The following is a description of a gene set: species: Mus musculus Mouse Gene Set: GOBP_REGULATION_OF_ATTACHMENT_OF_SPINDLE_MICROTUBULES_TO_KINETOCHORE Any process that modulates the frequency, rate or extent of the attachment of spindle microtubules to the kinetochore., and this is the list of marker genes: Cdc42, Cdk1, Cenpe, Sirt1, Racgap1, Birc5, Ccnb1, Rcc2, Spag5, Cdca8, Kat2b, Becn1, Incenp, Knstrn, Sirt2, Kat5, Nek2, Apc, Hnrnpu, Ect2, Aurkb, Ccnb1-ps